The following is a description of a gene set: species: Homo sapiens Human Gene Set: GSE32986_CURDLAN_LOWDOSE_VS_GMCSF_AND_CURDLAN_LOWDOSE_STIM_DC_DN A simultaneous engagement of different pathogen recognition receptors provides a tailor made adaptive immunity for an efficient defence against distinct pathogens. For example, cross talk of TLR and c-type lectin signalling effectively shapes distinct gene expression patterns by integrating the signals at the level of NF-κB. Here, we extend this principle to a strong synergism between the Dectin-1 agonist, curdlan, and an inflammatory growth factor, GM-CSF. Both together act in synergy in inducing a strong inflammatory signature which converts immature DCs to potent effector DCs. A variety of cytokines (IL-1β, IL-6, TNF-α, IL-2 and IL-12p70), costimulatory molecules (CD80, CD86, CD40 and CD70), chemokines (CxCl1, CxCl2, CxCl3, CCl12, CCl17) as well as receptors and molecules involved in fugal recognition and immunity such as Mincle, Dectin-1, Dectin-2 and Pentraxin 3 are strongly up-regulated in DC treated simultaneously with curdlan and GM-CSF. The synergistic effect of both stimuli resulted in strong IKBα phosphorylation, in its rapid degradation and in enhanced nuclear translocation of all NF-κB subunits. We further identified MAPK ERK, as one possible integration site of both signals, since its phosphorylation was clearly augmented when curdlan was co-applied with GM-CSF. Our data demonstrate that the immunomodulatory activity of curdlan requires an additional signal provided by GM-CSF to successfully initiate a robust β-glucan specific cytokine and chemokine response. The integration of both signals clearly prime and tailor a more effective innate and adaptive response against invading microbes and fungi. from publication Min L, Isa SA, Fam WN, Sze SK, Beretta O, Mortellaro A, Ruedl C (PMID 22250091) Genes down-regulated in bone marrow-derived dendritic cells: low dose of 1,3-beta-D-oligoglucan versus CSF2 and low dose of 1,3-beta-D-oligoglucan., and this is the list of marker genes: INPP5B, ZFYVE19, MRPS2, NEPRO, PRR14L, MAP2K3, NOL8, UTP15, SLC4A7, PPA1, TAF10, MARCHF3, ELAVL1, LSS (lanosterol synthase), NHP2, AACS, SNRPD3, SLC7A6, TBL3, MYCBP2, DUSP7, NOA1, BATF3, CYB5B, CTPS1, NFKBID, BMS1, PRMT3, HDAC1, C21orf91, PFDN4, CDH1, BHLHE22, RGL1, DIABLO, NOP16, ATP2A2, EIF6, SNAPC4, WDR43, STAT5A, LARP1, CMKLR1, RGCC, SOCS1, DYNC1LI1, CCT3, KCTD11, PSMG1, POLR1B, ODC1, DHX37, DDX27, SEH1L, POLR1F, LYAR, GSPT1, ACACA, CCT8, CD40, IFRD2, RABEP1, SLAMF8, JAK2, NUP58, EMILIN2, MCOLN2, TLR2, CEMIP2, PGS1, ABHD17C, MON1B, EIF5, QTRT2, CLEC10A, NUDT3, CHML, ASAP1 (ArfGAP with SH3 domain, ankyrin repeat and PH domain 1), MYD88, PHLDA1, NSUN2 (NOP2/Sun RNA methyltransferase 2), BTG1, UFM1, PPP1R14B, IL31RA, C11orf24, ACOD1, ETF1, CRELD2, GNB4, PHF5A, FDPS, PRRC2A, NFX1, EPRS1, VRK1, PFDN2, RAI14, PUS1, LSM7, KLF9, INO80, CHST7, EIF3B, ERCC8, CDV3, HSPA9, RCL1, KCNN4, PSTPIP2, FKBP4, HSD17B7, ERH, ERG28 (NCBI Gene Id 11161), PWP1, RWDD1, SNUPN, RRN3, TNFRSF13B, ZNF598 (zinc finger protein 598, E3 ubiquitin ligase), OSTC, SLC35B3, GNL2, F3, C19orf48P, KRTCAP2, NUP153, FOSL2 (NCBI Gene Id 79579), DCSTAMP, EGR1, ZMYND19, BTG3, INTS2, H1-8, PDIA4, RRP9, ANKH, MTAP, RBBP8, EMP1, SLC12A4, RBMXL1, GPR171, RARA, IL1B, TIMM8A, CNN3, SEPTIN9, SLA, MAX, TOMM40, LTB, PRPF31, DENND1A, RCC1L, MAPK1IP1L, LTA4H, FCGR2A, AMPD2, AFG2B, SDHAF2, TNFRSF4, REL (NCBI Gene Id 5966), TRAF5, MFSD2A, EXOSC7, DUSP6, DIMT1, EML4, RBM12, ABCC1, PDLIM7, PRDX6, ECE2, ETS2, HSPH1, SEC11A, UBE4A, EHD1, DGKA, KTI12, NAA15, SPHK1, MEG3, RMDN3, SLC7A1, HSPA8, RANBP1, CA2, CIITA (NCBI Gene Id 4261), GPR85, PTPN9, SYDE2, PAK2, KLF7, CLCN6, EID2, SRFBP1